The following is a description of a gene set: Human Gene Set: DESCARTES_FETAL_KIDNEY_MYELOID_CELLS from publication Cao J, O'Day DR, Pliner HA, Kingsley PD, Deng M, Daza RM, Zager MA, Aldinger KA, Blecher-Gonen R, Zhang F, Spielmann M, Palis J, Doherty D, Steemers FJ, Glass IA, Trapnell C, Shendure J (PMID 33184181) The gene expression program underlying the specification of human cell types is of fundamental interest. The study authors generated human cell atlases of gene expression and chromatin accessibility in fetal tissues. For gene expression, the study authors applied three-level combinatorial indexing to >110 samples representing 15 organs, ultimately profiling ~4 million single cells. The study authors leveraged the literature and other atlases to identify and annotate hundreds of cell types and subtypes, both within and across tissues. Our analyses focused on organ-specific specializations of broadly distributed cell types (such as blood, endothelial, and epithelial), sites of fetal erythropoiesis (which notably included the adrenal gland), and integration with mouse developmental atlases (such as conserved specification of blood cells). These data represent a rich resource for the exploration of in vivo human gene expression in diverse tissues and cell types. studied in species Homo sapiens Marker genes curated from the annotated cluster as represented in the Descartes Human Gene Expression During Development database., and this is the list of marker genes: MYO7A, GPBAR1, SLC43A2, MYBPC3, LILRA6, TREM1, CD86, CD200R1, SIGLEC16, FCN1, PLB1, SIRPB2, HAVCR2, HLA-DQB1, TNNI2, RN7SL368P, GGTA1, CD209, CD274, SIGLEC20P (sialic acid binding Ig like lectin 20, pseudogene), ARHGAP22, C15orf48, RUFY4, LY96, CLEC4GP1, HLA-DPB1, IFI30, ENSG00000232628, C1orf162, ACY3, CPVL, CLEC5A, HCK, PELATON, KCNAB1 (potassium voltage-gated channel subfamily A regulatory beta subunit 1), CCR5, LINC01478, CD68, LINC01678, TLR7, MS4A6A, ZEB2-AS1 (NCBI Gene Id 100303491), RNA5SP288, SLAMF8, HRH1, IGSF6, CRYBB1, MAP4K1-AS1, LINC02712, IL10, SLC37A2, CSF2RA, C3AR1, FCGR1BP, LRRC25, LILRA2, DHRS9, RNASE2, FOLR2, CST3, FCGR1A, NAPSB, CCR1, SLCO2B1, RGS2, P2RY13, SLC15A3 (solute carrier family 15 member 3), LILRA1, LRRK1, ATP8B4, CSF1R, RN7SL138P, LILRB2, TNFSF18, FGD2, P2RY6, LINC00671, CD163, PLAUR, IGSF21, ARL5C (ADP ribosylation factor like GTPase 5C), CYRIA, CIITA, OLR1, ST18, TNFRSF11A, HLA-DQB1-AS1, SOWAHD, TRIM50 (NCBI Gene Id 260316), KCNK17, MS4A14, LILRB5, HERC2P10, CYBB, LPCAT2 (lysophosphatidylcholine acyltransferase 2), HLA-DQB2, FPR3, ZDHHC19, RPL7AP75, SIRPB1, TIFAB, ADAP2, HMOX1, GPR34, AQP9, ENSG00000254288, HLA-DRB9, TLR8, CCL8, TREM2, FCGR2C, LNCATV, HPGDS, SNORD3B-2, OSCAR, AIDAP2, NOD2, HK3, MICOS10-DT, TLR10, CD33, CD300LF, NCF2, CD300E (CD300e molecule), KYNU, ADRB1, LILRB4, LINC01010, VNN1, ASGR2, MPEG1, SIGLEC9, NCF1, CLEC7A, LINC02513, CSTA, RPH3AL-AS1, LINC03070, VSIG4, RPL32P1, TLR1, SPI1, LINC02723, RETN, CIMAP1B, HLA-DMB, RPA4, IER3, SLC24A4, CCR2, NLRP3 (NCBI Gene Id 9558), SMIM35, FAM20A, C1QA, SIGLEC6, LINC01220, B3GNT5, DLGAP3, MNDA, PTAFR, MSR1, RASSF4, NAMPT-AS1, NFAM1, GPR183, MEFV, TMEM273, CLEC9A, HLA-DRB5, SIGLEC1, MMP2-AS1, MARCHF1, C1QB, C5AR2, RYR1 (ryanodine receptor 1), CLEC4F, MS4A7, PTGS2, CXCL8, AATBC, SCIMP, C9orf72, C1QC, SPP1, MS4A4A (membrane spanning 4-domains A4A), CTSB, TMT1B, HCAR2, SCN9A, PTPRN2-AS1, KCNJ5-AS1, MS4A4E, RNASE6, HLX-AS1, S100A8, MARCO, ABCA1, LINC01182, ENSG00000212293, IL1R2, RHBDF2, CRLF2, SLC22A18AS, CCDC17, LINC00996, CLEC4C, SIGLEC5, AIF1, STYXL2, LINC01299 (long intergenic non-protein coding RNA 1299), GPR84 (G protein-coupled receptor 84), CYTH4, CD163L1, LILRB1, ALDH3B1, LINC02798, LINC02983, MSLN, TMEM86A